Given this list of marker genes Plxna2, Fyn, Hsp90aa1, Pak3, Plxna3, Hsp90ab1, Plxna1, Pak1, Plxna4, Pak2 (p21 (RAC1) activated kinase 2), Rac1, Nrp1, Fes, Limk1, here is a description of the gene set: studied in species Mus musculus Mouse Gene Set: REACTOME_SEMA3A_PAK_DEPENDENT_AXON_REPULSION Sema3A PAK dependent Axon repulsion